Given this list of marker genes COL1A2, SEC24D, LRP5, CRTAP, P4HB, COL1A1, here is a description of the gene set: Crumpled long bones Human Gene Set: HP_CRUMPLED_LONG_BONES An crumpled radiographic appearance of the long bones, as if the long bone had been crushed together producing irregularities. This feature is the result of multiple fractures and repeated rounds of ineffective healing, as can be seen for instance in severe forms of osteogenesis imperfecta. studied in species Homo sapiens